The following is a description of a gene set: Reactome Pathway: Telomere Extension By Telomerase electronically inferred by orthology from the curated human pathway part of: Extension of Telomeres studied in species Mus musculus This event has been computationally inferred from an event that has been demonstrated in another species.<p>The inference is based on the homology mapping from PANTHER. Briefly, reactions for which all involved PhysicalEntities (in input, output and catalyst) have a mapped orthologue/paralogue (for complexes at least 75% of components must have a mapping) are inferred to the other species., and this is the list of marker genes: Shq1, Ppp6c, Acd, Pif1, Terf2, Terf1, Ccna1, Tert, Nop10, Wrap53